Given this list of marker genes Col5a2, Col6a6 (NCBI Gene Id 245026), Col16a1, Col26a1, Col4a6, Col6a2, Col12a1, Col3a1, Col1a1, Col4a1, Col4a4, Col11a1, Col6a3, Col8a1, Col25a1, Col17a1, Col9a2, Col9a1, Col11a2, Col9a3, Col7a1, Col5a3, Col19a1, Col8a2, Col4a3, Col14a1, Col4a2, Col2a1, Col23a1, Col13a1, Col18a1, Col22a1, Col20a1, Col5a1, Col4a5 (NCBI Gene Id 12830), Col1a2, Col6a5, Col28a1, Col6a1, Col15a1, Col10a1, here is a description of the gene set: studied in species Mus musculus Mouse Gene Set: REACTOME_COLLAGEN_CHAIN_TRIMERIZATION Collagen chain trimerization